Given this list of marker genes Zdhhc12, Mavs, Plcg2, Tlr6, Lamp2, Trim30a, Nlrc3, Ddx3x, Stmp1, Ptpn22, Zdhhc1, Tlr4, Nek7, Dhx33, Nlrp6, Abhd17a (NCBI Gene Id 76403), Kcnk13, Trem2, Sirt2, Prkd1, Nlrp1a, Fbxl2, Nlrp1b, P2rx7, Brcc3dc, Nlrp3, Brcc3, Gbp5, Lats2, Irgm2, Trim31, Mapk8, Zdhhc5, Cd36, Cptp, Atat1, Lats1, Gm12250, Mark4, Csnk1a1, Myd88, Eif2ak2, Casp4, Mefv, Igtp, Btk, Usp50, Irgm1, Kcnj8, Hspa8, Ppp2ca, Pycard, Gkn2, here is a description of the gene set: Mouse Gene Set: GOBP_CANONICAL_INFLAMMASOME_COMPLEX_ASSEMBLY species: Mus musculus The aggregation, arrangement and bonding together of a set of components to form an inflammasome complex.